The following is a description of a gene set: Any process that results in a change in state or activity of an organism (in terms of movement, secretion, enzyme production, gene expression, etc.) as a result of a stimulus by molecules of fungal origin such as chito-octamer oligosaccharide. species: Homo sapiens Human Gene Set: GOBP_RESPONSE_TO_MOLECULE_OF_FUNGAL_ORIGIN, and this is the list of marker genes: MYD88, SCIMP, SYK, CLEC7A, BTK